The following is a description of a gene set: from publication Kerley-Hamilton JS, Pike AM, Li N, DiRenzo J, Spinella MJ (PMID 15940259) species: Homo sapiens Genes genes up-regulated in NT2/D1 cells (embryonal carcinoma) in response to treatment with cisplatin. Testicular germ cell cancers remain one of the few solid tumors routinely cured in advanced stages with conventional cisplatin-based chemotherapy. The mechanisms remain largely unknown. Through use of gene-expression array profiling we define immediate transcriptional targets in response to cisplatin in testicular germ cell-derived human embryonal carcinoma cells. We report genes upregulated and five genes repressed by cisplatin. Several of these gene products, including FAS, TRAILR3, PHLDA3, LRDD, and IER3 are previously implicated in the apoptotic death receptor pathway, while others including SESN1, FDXR, PLK3, and DDIT4 are known mediators of reactive oxygen species generation. Approximately 54% of the upregulated genes are established or suspected downstream targets of p53. Specific siRNA to p53 prevents cisplatin-mediated activation of p53 and p53 pathway genes and renders embryonal carcinoma cells relatively resistant to cisplatin cytotoxicity. Interestingly, in p53 knockdown cells nearly the entire set of identified cisplatin targets fail to respond or have a diminished response to cisplatin, suggesting that many are new direct or indirect targets of p53 including GPR87, STK17A, INPP5D, FLJ11259, and EPS8L2. The data indicate that robust transcriptional activation of p53 is linked to the known hypersensitivity of testicular germ cell tumors to chemotherapy. Many of the gene products may participate in the unique curability of this disease. Human Gene Set: KERLEY_RESPONSE_TO_CISPLATIN_UP, and this is the list of marker genes: BTG2, PPM1D, PHLDA3 (pleckstrin homology like domain family A member 3), CAV1, IER3, FADS3, SESN1, GADD45A, ANXA4, PLAT, DGKA, LMNA, DRAM1, PDE4A, ANXA1, FOSL1, DDIT4, HSD17B3, GLS2 (glutaminase 2), PROCR (NCBI Gene Id 10544), TNFRSF10C, MS4A1, FDXR (ferredoxin reductase), SERPINE1, ANK1, STK17A, PLK2, FAS, NEFL, TRIM22, GDF15, PIDD1, ZMAT3 (zinc finger matrin-type 3), ACTA2, ISYNA1, ALDH1A3 (aldehyde dehydrogenase 1 family member A3), DDB2, CDKN1A, RPS27L, TP53TG1, EPS8L2, TIGAR, INPP5D, CXCL14, PLK3